The following is a description of a gene set: studied in species Mus musculus This event has been computationally inferred from an event that has been demonstrated in another species.<p>The inference is based on the homology mapping from PANTHER. Briefly, reactions for which all involved PhysicalEntities (in input, output and catalyst) have a mapped orthologue/paralogue (for complexes at least 75% of components must have a mapping) are inferred to the other species. electronically inferred by orthology from the curated human pathway part of: Metabolism of carbohydrates and carbohydrate derivatives Reactome Pathway: Lysosomal oligosaccharide catabolism, and this is the list of marker genes: Man2b1, Man2c1, Man2b2